Given this list of marker genes Gclc, Ggt1, Gclm, Chac1, Gss, Ggt6, Oplah, Cndp2, Ggct, Ggt5, Ggt7, Chac2, here is a description of the gene set: Mouse Gene Set: REACTOME_GLUTATHIONE_SYNTHESIS_AND_RECYCLING studied in species Mus musculus Glutathione synthesis and recycling